The following is a description of a gene set: Mouse Gene Set: GOCC_U2AF_COMPLEX studied in species Mus musculus A heterodimeric protein complex consisting of conserved large and small U2AF subunits that contributes to spliceosomal RNA splicing by binding to consensus sequences at the 3' splice site. U2AF is required to stabilize the association of the U2 snRNP with the branch point., and this is the list of marker genes: Sf1, U2af2, Zrsr2, U2af1, U2af1l4, Pdcd7